Given this list of marker genes AARS1, MYOT, POMT1, ALG14 (ALG14 UDP-N-acetylglucosaminyltransferase subunit), COL6A2 (collagen type VI alpha 2 chain), KLC2, FKRP, COL6A1, IDH1, COL12A1, GTF2H5, NUP88, VPS11, PMM2, LSM11, KY, RNASEH2C, RNASEH2A, IFIH1 (NCBI Gene Id 64135), SELENON, RNF113A, ZMPSTE24, TARS1, RBM28, SLC1A4, DNA2, ERCC2, MYBPC1, TUBA1A, TRIP4, UBA1 (ubiquitin like modifier activating enzyme 1), CHRNG, ADAR, B3GALT6, COL6A3, MYH7, RFC1, EXOSC9, ERCC3, DOK7, SLC39A14, TGM1, LARGE1, PIGS, TOR1A (NCBI Gene Id 1861), RTTN, RAPSN, POMT2, TTN, KIF21A, FLRT1, LMNA, RNASEH2B, PIP5K1C, MED12, MYOD1, NDE1, TREX1, GMPPB, BICD2 (BICD cargo adaptor 2), RNU7-1, GTF2E2, FLNA, MPLKIP, MAGEL2, MUSK, SLC18A3, CARS1, GPKOW, SAMHD1, RYR1, here is a description of the gene set: species: Homo sapiens Human Gene Set: HP_MULTIPLE_JOINT_CONTRACTURES Multiple joint contractures